Given this list of marker genes ADCYAP1R1, ADCYAP1, ADORA2A, NGF, NTRK2, NTRK1, here is a description of the gene set: studied in species Homo sapiens Human Gene Set: REACTOME_ACTIVATION_OF_TRKA_RECEPTORS Activation of TRKA receptors